Given this list of marker genes SETX, GBA2, GCSH, SELENOI, PRPS1, HTT, ALS2, SPTLC1, TRAK1 (trafficking kinesin protein 1), AMPD2, SMG9, SLC25A15, WASHC5, SLC39A14, GOLGA2, POMGNT1, CARS1, KIF1C, SPAST, MICU1, SIGMAR1, RAB3GAP2, SLC1A4, KLC2, NFU1, POMK, OCRL, TCEAL1, SV2A, ADGRG1, CYP27A1, PIGP, SLC16A2, SLC33A1, FKRP, CCT5, MED17, OSTM1, RUSC2, CAPN1, SLC52A3, PET100, BRAT1, TIMM50, SPTBN1, AARS1, TSEN2, KDM1A, ATP6AP2, NT5C2, RTN2, UBAP1, TANGO2, PSAP, FUS, KPNA3, PEX16, ASNS, DNM1, ZFYVE26, ABCB7, ANO10, ABCD1, VCP, PC, COQ4, CAMLG, EBF3, GALC, SPG11, SLC25A21, CYP7B1, POMT2, SEPSECS, DTYMK, SYNE1, TIMM8A, NADK2 (NCBI Gene Id 133686), VAC14, RNASEH1, HIKESHI, KCNQ2, MARS1, KIF5A, SOD1, RNU4-2, PIGT, FA2H, CRELD1, SLC6A9, LMNB1, UFC1, CCDC88C, PRUNE1, SPTBN2, MTRFR, AHDC1, NDP, KCNT1, STUB1, UCHL1, EMILIN1, SLC44A1, REEP1, POU3F4, PI4KA, ERLIN2, SPART, ERLIN1, ITPR1, FGF13, CAV1, MYL2, GFM2, NIPA1, USP8, GMPPB, PLA2G6, POMT1, EXTL3, VPS37A, PTS, HTRA2, ATL1, KCNQ3, NDUFS8, CD40LG, SLC2A3, RAB18, KIF1A, SAMD9L, here is a description of the gene set: studied in species Homo sapiens Human Gene Set: HP_CLONUS Clonus A series of rhythmic and involuntary muscle contractions (at a frequency of about 5 to 7 Hz) that occur in response to an abruptly applied and sustained stretch.